Given this list of marker genes SDHC, ATM, SDHD, ALX1, NRAS, PTCH2, BRCA2, CPLANE1, WDPCP, VHL (von Hippel-Lindau tumor suppressor), KIF7 (NCBI Gene Id 46), KIAA0753, TMEM231, TOPORS, SOX2, CDKN2B, IFNG, TSC1, TRAF7, USF3, MEN1, LMNA, ZSWIM6, MUTYH, SLC25A11, KRIT1, EPCAM, TIAM1, CDKN1A, KDM1A, SDHAF2, SMARCE1, SUFU, GCDH, CCM2, PDGFRB, EP300, TSC2, POLD1, NOTCH3, PDGFB (platelet derived growth factor subunit B), MDH2, FAT4, TMEM216, GNAS, KLLN, SDHA, CREBBP, RPS20, CDKN1B, MAX, ALX3, SMO, SDHB, CHEK2, PDE6D, MN1, PTEN, CCND1, COQ6, VPS16, WRN, OFD1, GLI3, LZTR1, FGFR1, RET, DLST, CCBE1, TMEM127, PTCH1, AKT1, KIF1B, MSH6, MSH2, PDCD10, FH, SEMA4A, MBD4, NTHL1, ADAMTS3, NF1, EIF3F, BMPR1A, KRAS, PMS2, TCTN3, BAP1, ARMC5, PIK3CA, TGFBR2, FAM149B1, SMARCB1, MLH1, TP53, TERT, OCRL, MAN2C1, SIX6, SEC23B, PMS1, NF2, POLE, CDKN2C (cyclin dependent kinase inhibitor 2C), here is a description of the gene set: Benign neoplasm of the central nervous system Human Gene Set: HP_BENIGN_NEOPLASM_OF_THE_CENTRAL_NERVOUS_SYSTEM studied in species Homo sapiens